Given this list of marker genes MEST, TYMS, NFE2L2, SLC30A9, TLE1, METAP1, ORM2, MRPL12, CXCL8, IMMT (NCBI Gene Id 10989), BAMBI, ILF3, NDUFA9, STMN1, IGF2, GGH, PSMC4, CYB5A, DDX39A, VBP1, LSM3, TJP2, SERPINH1, OCLN, H2AC16, SDC1 (NCBI Gene Id 6382), PLK1, UBXN1, DCAF11, RCC1, SORD, APOA1, CEBPG, ADAM9, BYSL, DNPH1, DDX21, BMI1, EEF1E1, PCNA, ARL4A, MAPK6, EPCAM, UBE2E1 (NCBI Gene Id 94682), SLC7A5 (NCBI Gene Id 8140), BTBD3, FEN1, SMARCA4, APOH, TSPAN3, ARPP19, HMGCR, RABGGTB, PSMA4, SEC24C, SLC29A1, PAIP1, IGF2BP3, ECI1, SRP54, APEX1, SLC11A2, TM4SF1, SNRPD3, IPO5, CD151, PSMB7, IER3, C5, MSH6, ATP6V1D, DPM1, PDS5A, TDG, FN1, ALCAM, CCNA2, CSRP2, FADD, BOP1, GDF15, CD24, MRPL3, SHMT2, F2, NHP2, NUPR1, GMFB, ELOVL2, BUB1B, DBN1, UMPS, KIF21B, HNRNPA0, PAH, LMNB2, HPRT1, MTHFS, ANXA3, MAOB, PTPRK, RO60, SRSF2, SLC25A1, CCN1, APOC1, ZYX, CKAP5, RARRES2, CDK2, PTP4A1 (NCBI Gene Id 7803), E2F3, CTCF, CXCL1, PSMD14, TPM1, NHERF1, RCN1, MYO1B, TM4SF4, ASGR1, TMED5, SEC23A, FOXM1, PDCD10, BIRC2, MYC, HAT1, GOT1, SLBP, RBCK1, NOLC1, APRT, NUP205, ACTN1 (actinin alpha 1), PLOD2 (procollagen-lysine,2-oxoglutarate 5-dioxygenase 2), PES1, GJB1, POLR2K, GJA1, ACAT2, DUSP6, TTK, LMNB1 (NCBI Gene Id 445266), TMEM97, KRT19, ZMPSTE24, SP3, IPO7, RRM1, BLOC1S1, EIF4EBP1 (NCBI Gene Id 1978), CDC42EP1, SERPINA1, SRPK1, MDK, COPS2, SUZ12, DTYMK, WEE1, SNRPF, RFC4, SLC43A1, LYRM1, MYL6B, ETFA, GCH1, HDDC2, VIL1, SLC1A5, AK2, PROM1 (prominin 1), EIF3I, TFDP1 (transcription factor Dp-1), CDKN3, PDIA4, PUM3, PSMA3, GPC3, TARBP2, CENPF, SLC39A7, SC5D, CLPP, PARP2, SLC39A6, ST6GAL1, SNU13, ADSL, AREG, TXNDC9, ITPA, STK17A, PON2, IL1RAP, LSM7, YWHAE, ETFB, FGFR3, LIF, UBE2N, GYG1, HMGA2, TOP2A, DNM2, AURKB, CYP1A1, DHX9, GSPT1, SRSF7, ARFIP2, COPS3, MAP4K4 (mitogen-activated protein kinase kinase kinase kinase 4), ALPL, AHR, DDT, CHAF1A, SNRPC, PNP, SLC4A2, CAD, PTPN12, ACSL3, FADS1, TMEM106C, CKS2, PSPH, ALG8, TRIP6, MRPL40, DDX42, ENPP2, SERPINA6, ADNP, CCL20, ABCC6, ACBD3, KLF10, JUNB (NCBI Gene Id 90482), MBD4, ITGB5, COPB1, MARF1, NUP153, PRPSAP1, ITIH2, CXADR, TOR1AIP1, DNMT1, TMX1, LPGAT1, TFAP4, GTF2E2, IQGAP2 (IQ motif containing GTPase activating protein 2), AMBP (alpha-1-microglobulin/bikunin precursor), ITPR3, GET1, TRIP13, ARPC1A, PRKDC, SDHB (succinate dehydrogenase complex iron sulfur subunit B), CCNB2, GRSF1, MAP2K3, ALDH1A1, CBX1, RND3, PIGC, CALU, DAP3, TNFAIP8, TBCE, PEG10, SOX4, MCM3, ATP13A3, PSMD4, TLK1, HPN, COL5A2, UBE2C, PTS, MSH2, FXYD2, MMD, ANXA4, FILIP1L (NCBI Gene Id 11259), CCT6A, DDX17, NRIP1, RIDA, UNG, UCK2, NDUFS6 (NCBI Gene Id 4726), COX11, LSM1, RHOD, KRT18, TMED3, RPA1, SCP2, LDLR, H4C3, ECHS1, PLIN2, SEMA6C, LAD1, HTATIP2, RAB11A, SSBP1, PAICS, GALNT1, SGCE, PSPHP1, PSMC2, GC, RPA3, UBD, RBP4, RBP1, AIMP2, APOE, LRPAP1, ITGA6, CPD, APOB, NUDT1, MCM6, CBX3, MAD2L1BP, ALB, LRPPRC, EBP, EPS8, ADIPOR2, ZWINT, STAU1, MCM7, DSP, HSD17B10, FGB, E2F5, EHBP1, TK1, CNN3, CRIM1, PEPD, PSMD7, PHLDA2, PLCB1, MAD2L1, RRP7A, RBBP4, PTTG1, CDV3 (CDV3 homolog), DYNLT3, CLN3, MFAP2, GCHFR, CTSC, ACTR2, IL4R, RCN2, PCLAF, MAPRE1, RRP1B, POLE3, CDKN2A, RBBP7, CDC20, NTS, CDH2, NUTF2, ABCF1, RAB5C, POLD2, AHCY, CDK1, ASNS, COX7B, UBE2M, UGDH, ASGR2, TGFBI, FDPS, IARS2, SSR1, CCNB1, MCM2, SNRPB2, ABCD3, DECR1, AGL, TSG101, VTN, NDUFB7, RGS2, SEC11A, PSMC6, CSE1L, NDUFS2, DEFB1, WTAP, ALDH4A1, SQLE, AGT, TPX2, GMPS, FAT1, SRP19, IL32, GTF2A2, ID2B, SELENOP, CAV1, EPHA2, COPS5, CDC123 (cell division cycle 123, NCBI Gene Id 8872), SEC13, TFRC, CHKA, here is a description of the gene set: Genes in the cancer module 8. Human Gene Set: MODULE_8 studied in species Homo sapiens